The following is a description of a gene set: species: Homo sapiens Human Gene Set: chr18q23, and this is the list of marker genes: RBFA, ENSG00000287281, NFATC1, LINC01898, SLC25A6P4, ENSG00000267015, LINC01029, SMIM21, CTDP1 (CTD phosphatase subunit 1), RPL26P35, ZNF236-DT, RNU6-346P, CCND3P2, ZNF236, GALR1, ZNF516-DT, LINC00683, ZNF516-AS1, RNA5SP461, SLC66A2, RBFADN, RNU6-655P, KCNG2, LINC01896, PARD6G, PARD6G-AS1, ENSG00000266844, LINC03101, LINC01927, MBP, ENSG00000304954, ATP9B, CTDP1-DT, HSBP1L1, ADNP2, LINC01893, ENSG00000266014, BDP1P, TXNL4A, ENSG00000263547, ARL2BPP1, SALL3, ZNF516